The following is a description of a gene set: Proliferation of higher eukaryotic cells is triggered by the proto-oncogene c-myc (myc), which is induced downstream of a large number of growth factor receptors. Myc, a basic helix-loop-helix leucine zipper transcription factor, transmits growth signals by up- and downregulation of target genes. The importance of Myc in growth control is well established. However, the number of growth control genes requiring Myc as an essential factor for regulation after mitogenic stimulation of cells is not yet clear. Here, we have studied the transcriptional programme of a human B-cell line, P493-6, in response to Myc and serum. P493-6 cells do not express the endogenous myc, nor is it induced by serum stimulation. Proliferation of the cells is dependent upon both the expression of a tetracycline-regulated myc gene and serum stimulation. Using DNA microarrays, expression profiling was performed following stimulation of cells with serum, with Myc, or with both. We observed serum regulation of >genes. A number of these genes were synergistically or antagonistically regulated by Myc. Moreover, we identified >300 Myc-regulated genes that were almost unresponsive to serum. Gene ontology analysis revealed that a high proportion of Myc target genes are involved in ribosome biogenesis and tRNA metabolism. The data support our current notion that Myc is essential for the regulation of a large number of growth-related genes in B cells, and cannot be replaced by other serum-induced factors. Human Gene Set: SCHLOSSER_MYC_AND_SERUM_RESPONSE_SYNERGY studied in species Homo sapiens Cluster 3: genes strongly up-regulated in B493-6 cells (B lymphocytes) by a combination of MYC and serum but not by each of them alone. from publication Schlosser I, Hölzel M, Hoffmann R, Burtscher H, Kohlhuber F, Schuhmacher M, Chapman R, Weidle UH, Eick D (PMID 15516975), and this is the list of marker genes: POLR2I, EOLA1, METAP2, LIMK2, EIF4A1, ARMC6, ARFIP2, KHSRP, SCAMP3, TMEM183A, MRPS12, TOMM40, SNRPA, SGTA, MTA1, DDX28, NME4, TAGLN2, CCDC85B, PYCR1, NCLN, COG2, RNF126, ZNF22, FARSA, SRM, SEPTIN11, LARP1, NDUFS5, SMG7, MRPL12, FPGS, FRAT2